The following is a description of a gene set: species: Homo sapiens from publication Gavish A, Tyler M, Greenwald AC, Hoefflin R, Simkin D, Tschernichovsky R, Galili Darnell N, Somech E, Barbolin C, Antman T, Kovarsky D, Barrett T, Gonzalez Castro LN, Halder D, Chanoch-Myers R, Laffy J, Mints M, Wider A, Tal R, Spitzer A, Hara T, Raitses-Gurevich M, Stossel C, Golan T, Tirosh A, Suvà ML, Puram SV, Tirosh I (PMID 37258682) Genes upregulated in subsets of cells of a given type within various tumors Human Gene Set: GAVISH_3CA_METAPROGRAM_CD8_T_CELLS_UNASSIGNED_2 In this study, an extensive analysis was conducted to define meta-programs (MPs) capturing intra-tumor heterogeneity across a spectrum of tumor types. The approach utilized non-negative matrix factorization (NMF) to analyze each cell type separately within individual tumor samples. This involved the analysis of malignant cells, macrophages, fibroblasts, endothelial cells, epithelial cells, T-cells, and B-cells. NMF was executed with varying parameter values (K=4, 5, 6, 7, 8, 9), thereby generating 39 programs for each cell type per sample. Each NMF program was summarized by the top genes based on NMF coefficients.\nRobust MPs were then delineated for each cell type using a set of stringent criteria, including recurrence within the same tumor, similarity to programs in other tumors, and non-redundancy within a tumor. Subsequently, these robust NMF programs were clustered (per cell type) based on Jaccard similarity, leading to the identification of MPs associated with each cell type.\nTo enhance the quality of the MPs, a refinement steps were undertaken, involving the removal of MPs suspected of reflecting low-quality data (with an overrepresentation of ribosomal proteins or mitochondrial-encoded genes), single-study inclusion, or similarity to miss-annotated cell types., and this is the list of marker genes: FKBP1A, LGALS1, TUBB, LSP1, S100A11, TBC1D10C, PPP1CA, TPI1, SLC25A5, GZMA, S100A4, SH3BGRL3, ATP5MC3, ITM2C, ACTB, RAC2, LY6E, PSME1, MYL12A, CALM3, C12orf75, TXN, CAPG, PPP1R18, ENO1, CAPZB, IL32, CLIC1, ARPC4, ANXA5, GZMH, SNRPE, EMP3, PSMA7, PSME2, PARK7, CORO1A, PFN1, PKM, COTL1 (NCBI Gene Id 90755), ARPC5, CAP1, STMN1, ARPC1B, APOBEC3G, BLOC1S1, MT2A, CKLF, PGAM1, CD52